The following is a description of a gene set: <p>Loss of function mutations in histone-lysine-N-methyltransferase (KMT2D), an epigenetic modifier associated with active transcription, is the major cause of Kabuki syndrome, a rare disorder that affects 1 in 32,000 births. Kabuki syndrome is characterized by distinct facial features such as long palpebral fissures with eversion of the lateral third of the lower eyelid and short columella with depressed nasal tip, skeletal anomalies, intellectual disability, and postnatal growth deficiency. Besides Kabuki syndrome, germline mutations in KMT2D are associated with another rare multiple malformation syndrome characterized by branchial arch abnormalities, choanal atresia, athelia, hearing loss, and hypothyroidism. Functionally characterized KMT2D mutations, as well as mutations occuring in the same residues, are annotated.</p><p>The pathway “Loss of Function of KMT2D in MLL4 Complex Formation in Kabuki Syndrome” describes KMT2D loss-of-function mutations reported in Kabuki syndrome that impair its ability to bind the WRAD complex.</p> Reactome Pathway: Loss of Function of KMT2D in Kabuki Syndrome part of: Disorders of Developmental Biology species: Homo sapiens, and this is the list of marker genes: DPY30, ASH2L, RBBP5, WDR5, KMT2D